The following is a description of a gene set: part of: Interleukin-1 family signaling This event has been computationally inferred from an event that has been demonstrated in another species.<p>The inference is based on the homology mapping from PANTHER. Briefly, reactions for which all involved PhysicalEntities (in input, output and catalyst) have a mapped orthologue/paralogue (for complexes at least 75% of components must have a mapping) are inferred to the other species. Reactome Pathway: Interleukin-33 signaling electronically inferred by orthology from the curated human pathway studied in species Mus musculus, and this is the list of marker genes: Il33, Il1rl1